Given this list of marker genes Nos1ap, Tac1, Agt, Kcne2, Mybpc3, Gch1, Oxt, Trpm4, Gjd3, Ednrb, Cacna1c, Scn10a (sodium channel, voltage-gated, type X, alpha), Chrm3, Ptpn1, Ednra, Bin1, Mc3r, Apln, Isl1, Tnni3k, Adm, Edn3, Hcn4, Agtr2, Mdm4, Cav3, Trpv1, Sptbn4, Kcne5, Scn1b, Kcnq1, Edn2 (NCBI Gene Id 13615), Ank2, Uts2, Tpm1, Ffar3, Epas1, Myh6, Fkbp1b, Kcnh6, Tnf, Kcne1, Casq2, Tmem161b, Shox2, Crhr2, Kcnj2, Myh7, Hey2, Kcnj5, Pmch, Edn1 (NCBI Gene Id 13614), Gja5, Akap9, Chrna7, Atp5pf, Scn2b, Calm2, Dsp, Scn5a, Calm3, Scn4b, Kcnh2, Snta1 (NCBI Gene Id 99348), Ace, Sema3a, Popdc2, Cacna1g, Cav1 (NCBI Gene Id 12389), Pln, Kcnd3, Kcne3, Slc1a1, Avpr1a, Kcna5, Slc8a1, Pkp2, Adra1b, Gpd1l, Ctnna3, Sri, Src, Cacnb2, Ada, Srebf1, Mdm2, Hrc, Nmu, Jup, Pde4d, Nppa, Dsg2, Ryr2, Calm1, Kcnj8, Rnls, Cacna2d1, Spx, Dsc2, Dmd, Scn3b, Sirt1, Pik3r1, Adrb1, Tacr3, Rgs4, Kcne4, Irx5, Npff, Adra1a, Bves, Adm2, Cacna1e, Cacna1d (calcium channel, voltage-dependent, L type, alpha 1D subunit), Drd2, here is a description of the gene set: species: Mus musculus Any process that modulates the frequency or rate of heart contraction. Mouse Gene Set: GOBP_REGULATION_OF_HEART_RATE